Given this list of marker genes Wrap73, Top2a, Haus1, Syde1, Smarcd3, Misp, Chmp4c, Ofd1, Mad1l1, Stag1, Khdc3, Stard9, Cdca8, Cdca5, Pinx1, Nusap1, Cenpi, Cep85, Smc4, Snhg15, Zfp207, Bcl7a, Nek6, Rgs14, Rps3, Meikin, Gen1, Cenpj, Tubgcp5, Uhrf1, Ccdc61, Cdc20, Csnk2a2, Hspa1b, Morc2b, Ska1, Mis18a, Stag3, Chmp3, Cenpf (centromere protein F), Pum2, Aspm, Poldip2, Haspin, Spo11, Mad2l1, Kntc1, Cep97, Cenpu, Prdm9, Iho1 (interactor of HORMAD1 1), Cenpe, Bcl7c, Rnf4, Csnk1d, Ran, Oip5, Kif18a, Nsl1, Cdc6, Sac3d1, Rnf212b, Washc5, Pbrm1, Akap8, Mcmdc2, Mad2l1bp, M1ap, Chmp1b, Anapc7, Cdc42, Haus4, Cep63, Smarce1, Bcl7b, Dctn2, Chmp1a, Chek2, Ccnb1, Tubgcp3, Cpeb1, Aurkb, Ccdc66, Fancd2, Sass6 (SAS-6 centriolar assembly protein), Ppp1r7, Cenpk, Eml3, Ccnb2, Cenps, Meioc, Ddx3x, Washc1, Nup62, Bcas2, Xrcc3, Flna, Top3a, Mau2, Majin, Kif23 (NCBI Gene Id 97568), Cenpw, Mre11a, Sirt1, Actr3, Ntmt1, Chmp4b, Tacc3, Eml4, Ehmt2, Psrc1, Smarcd2, Chmp5, Arid2 (NCBI Gene Id 77044), Syce2, Cep192, Tex11, Diaph3, Bccip, Ciao1, Slc25a5, Bub3, Nsmce2, Knstrn, Syce3 (synaptonemal complex central element protein 3), Ska2, Seh1l, Tpr, Ccnb1-ps, Actr2 (NCBI Gene Id 66713), Rec8, Rad18, Chfr, Tex12, Esco2, Golga2, Ccne1, Hormad1, Terf1, Prap1 (proline-rich acidic protein 1), Mis12, Pcid2, Top2b, Tubgcp4, Shoc1, Fam83d (NCBI Gene Id 99445), Rmi2, Nuf2, Ube2b, Ddb1 (damage specific DNA binding protein 1), BC005624, Arl8b, Rab11a, Hnrnpu, Phf13, Sun1, Mms19, Rad21, Map1s, Sgo2a, Tex19.1, Ccne2, Ncapd3, Mlh3, Dlgap5, Ciao2b, Apc, Map10, Plscr1, Mei4, Zwint, Tubb5, Spc25, Spata22, Anapc11 (NCBI Gene Id 97770), Senp6, 1700028K03Rik, Pttg1, Cenpp, Gtf2b, Tubg2, Klhl22, Setdb2, Ndc80, Cltc, Atm, Chmp1b2, Smc1a, Hdac3, Stag2, Nde1, Ripor2, Chmp6, Espl1, Dpf3, Kat5, Septin1, Katnb1, Cenpm, Dusp1, Usp44, Ube2u, Clasp1, Dsn1, Pibf1 (progesterone immunomodulatory binding factor 1), Pten, Anapc5, Mtcl2, Tpx2, Srpk1, Kif4, Chmp2b, Smc2, Haus5, Mnd1, Pum1, Kash5, Mapre3, Ankrd31, Sirt2, Spag5, Rb1, Smarcd1, Becn1 (NCBI Gene Id 56208), Terb2, Knl1, Kif2c, Zwilch, Stil, Brd7, Brca1, Spc24, Anapc2 (NCBI Gene Id 99152), Ncaph, Ncor1, Kat2b, Cdt1, Ncapg2, Bag6, Mos, Trip13, Clasp2, Nup43, Smarca2, Meiob, Arhgef10, Chtf18, Atf6b, Baz1b, Kif11, Gpsm2, Kif14, Kif18b, Kif2b, Actl6a, Zcwpw1, Ppp2r1b, Chmp2a, Haus7, Birc5, Rrs1, Actb, Tlk1, Tlk2 (tousled-like kinase 2 (Arabidopsis)), Spdl1, Cenpx, Bex4, Ccdc69, 4930447C04Rik, Wapl, Cul3, Tubgcp6, Phf10, Nup37, Smc5, Ino80, Psmc3ip, Arid1a, Lats1, Top1, Ciao2a (NCBI Gene Id 68250), Usp9x, Ncapd2, Tubgcp2, Bex6, Trappc12, Spice1 (NCBI Gene Id 52573), Cdc16, Ccsap, Msh5, Ndc1, Ppp2r2d, Naa60, Ncaph2, Ankrd53, Smarca4, Racgap1, Aaas, Dmc1, Ndel1, Psmg2, Aurka, Chmp7, Arl8a, Brip1, Firrm, Mapre1, Csnk2a1, Mtcl1, Dis3l2, Smarca5, Dpf2, Mki67, Ttk, Rangrf, Cenpt, Prpf4b, Cdk1, Haus3, Sirt7, Rnf212, Fmn2, Ncapg, Anapc15-ps, Nipbl, Syce1, Abraxas2, Kif22, Cenatac, Kpnb1, Cit, Spdya, Rhoa, Abraxas1, Ska3, Champ1, Pmf1, Cenpn, Riok2, Ccnb1ip1, Mael, Rcc2, Ube2c, Terb1, Cenpo, Actl6b, Ctcf (CCCTC-binding factor), Haus8, Smarcb1, Rad21l, Brca2, Plk1, Brd4, Kif2a, Nek2, Smc6, Hjurp (Holliday junction recognition protein), Cdk5rap2, Numa1, Smarcad1, Sycp1, Itgb3bp, Mapre2, Ago4, Map9, Sgo1, Anapc15, Ik, Top3b, Dcaf13 (DDB1 and CUL4 associated factor 13), Uvrag, D1Pas1, Haus2, Ect2, Kif15, Anapc4, Gem, Smc3 (NCBI Gene Id 13006), Bub1b, Cenpl, Dync1h1, Lsm14a, Tex14, Vps4a, Dpf1, Arhgap33os, Lcmt1, Ppp2r1a, Kifc5b, Mei1, Bub1, Incenp, Anapc1, Hspa1a, Ttl, Bend2, Mybl2, Tubg1, Haus6 (HAUS augmin-like complex, subunit 6), Smarcc2, Dicer1, Cdc27, Mzt1, Dync1li1, Fbxo5, Msh4, Cenpq, Nudc, Tex15, Vps4b, Cenpc1, Mapk15, Ppp2r2a, Kifc1, Prc1, Ube2i, Klhdc8b, Ercc2, Prickle1, Mlh1, Lzts2, Rcc1, Cdca2, Drg1, Kif3b, Akap8l (NCBI Gene Id 54194), Zw10, Cenph, Tubb1, Recql5, Fbxo30, Sycp3, Smarcc1, Hecw2, Cdc23, Syce1l, here is a description of the gene set: species: Mus musculus Mouse Gene Set: GOBP_CHROMOSOME_SEGREGATION The process in which genetic material, in the form of chromosomes, is organized into specific structures and then physically separated and apportioned to two or more sets. In eukaryotes, chromosome segregation begins with the condensation of chromosomes, includes chromosome separation, and ends when chromosomes have completed movement to the spindle poles.